The following is a description of a gene set: A kind of congenital cataract that is characterized by a hollow sphere of punctate opacities involving the fetal nucleus and that usually occurs bilaterally. Human Gene Set: HP_PULVERULENT_CATARACT Pulverulent cataract species: Homo sapiens, and this is the list of marker genes: CRYBB1, CRYBB2, MAF, GJA5, LIM2, CRYGC, HSF4, GJA8, BEST1, VIM, FTL